Given this list of marker genes MEG3 (NCBI Gene Id 55384), TRPV6, CCN2, RTL1, DLK1 (NCBI Gene Id 8788), here is a description of the gene set: Human Gene Set: HP_UNDULATE_RIBS studied in species Homo sapiens An abnormally wavy surface or edge of the ribs. Undulate ribs